The following is a description of a gene set: species: Homo sapiens Human Gene Set: HP_ABNORMALITY_OF_TASTE_SENSATION Abnormality of taste sensation, and this is the list of marker genes: RETREG1, TRANK1, SCN9A, ELP1, WNK1, KIF1A, SLC39A4